Given this list of marker genes PRRT2, C2CD5, ANXA2, SYT4, SYT13, SNCA, DOC2A, ZNRF2, SYT8, DOC2B, SYT11, SYT3, ERC2 (NCBI Gene Id 26059), ZNRF1, SYT7, RPH3A, SYT5, RPH3AL, SYT2, ANXA1, SYT1, SYT9, here is a description of the gene set: Human Gene Set: GOBP_POSITIVE_REGULATION_OF_VESICLE_FUSION species: Homo sapiens Any process that activates or increases the frequency, rate or extent of vesicle fusion.